Given this list of marker genes TRAFD1, CYP2S1, FBXO45, CD8A, GAS6, PTDSS2, MFSD1, SLC31A1, ARHGAP1, RABGGTA, RNF141, KIN, CBR1, ANKRD28, DPM3, FLOT1, POLR1H, IL1RN, RPGR, DDX19B, MAIP1, S100A1, DNAJC15, MELK, STAB1, ATP5IF1, HMBOX1, TWSG1, MYBPC3, TXNL1, EMP3, SUGT1, DNAJB2, KCNA5, GPM6B, CEBPG, INTS11, PCBP2, PITPNA, SYS1, HK2, KCNMB1, PLA2G7, ABCB8, ZNF644, FH, DYNC1H1, YIPF4, ICE1, GNE, CCN3, GADD45A, CAPN5, MRAS, HAUS6, TMX1, SLC38A4, MCOLN2, VPS37C, PXN, TXNIP, CRCP, GYG1, S100A4, ST3GAL5, USP48, POLG, SAA1, MRPS25, LTC4S, STK16, TEKT2, NFIB, ANXA6, CRYGD, RUFY1, PDE6D, LCP2, GMFG, AGR2, HSD17B11, COX16 (NCBI Gene Id 51241), RMND5A, PAX5, GSTM5, IARS1, ETFB, ID3, GSDME, RPL18, CHMP6, RABGGTB, PGLYRP1, APCS, SLC25A36, FGF18, MRPS11, DAP, FBXL3, RCAN3, BNIP3L, CTDSP2 (NCBI Gene Id 51589), ACIN1, MYD88, GSTO1, EIF3D, GDPD3, LLGL2, IFIT1B, TULP2, PMM2, PKIG, TNFSF4, PDCD4, MYADM, ACAA2, RC3H2, PPIE, FCHO1, BCL2L11, VAMP2, PSTPIP1, HLA-E (major histocompatibility complex, class I, E), USE1, ARNT2, SBF2, RLIM, MYOG, ATF1, SCN1A, CORT, BMP2K, RPL6, PLCG2, NCF4, C19orf73, WNT6, PNLIPRP1, AHNAK, PLXND1, RALGDS, FXYD2, NAPSA, CD1D, ARL2BP, ALOX12, MAP3K1, CYB5B, SNAPIN, CDIP1, TBC1D14, CSDE1, RPL36, STK10, TGFBI, SMARCD1, IDO1, STX12, BARD1 (BRCA1 associated RING domain 1), VWF, COX6A1, KCTD10, PEX11A, NDUFA6, WDR13, PUM2, LPCAT3, MIEN1, KPNA3, PSMD1, ADIPOQ, FASTKD5, ABCC6, ATP4B, RAB3D, LBR, RXRB, RACK1, C2orf80, TMEM9B, CYP51A1, ADRA2A, H1-4, PRX, VMP1, SESN1, GRK6, FBXO9, ANGEL2, SOCS3, CLTC, COLQ, RBM17, CPNE3, SIRT3, NCOA6, BTC, TP53INP2, GLRX3, PNP, here is a description of the gene set: studied in species Homo sapiens Human Gene Set: GSE43955_TGFB_IL6_VS_TGFB_IL6_IL23_TH17_ACT_CD4_TCELL_60H_UP Genes up-regulated in CD4 T helper cells Th17 (60h): TGFB1 and IL6 versus TGFB1, IL6 and IL-23. from publication Yosef N, Shalek AK, Gaublomme JT, Jin H, Lee Y, Awasthi A, Wu C, Karwacz K, Xiao S, Jorgolli M, Gennert D, Satija R, Shakya A, Lu DY, Trombetta JJ, Pillai MR, Ratcliffe PJ, Coleman ML, Bix M, Tantin D, Park H, Kuchroo VK, Regev A (PMID 23467089) Despite their enormous importance, the molecular circuits that control the differentiation of Th17 cells remain largely unknown. Recent studies have reconstructed regulatory networks in mammalian cells, but have focused on short-term responses and relied on perturbation approaches that cannot be applied to primary T cells. Here, we develop a systematic strategy – combining transcriptional profiling at high temporal resolution, novel computational algorithms, and innovative nanowire-based tools for performing gene perturbations in primary T cells – to derive and experimentally validate a temporal model of the dynamic regulatory network that controls Th17 differentiation. The network is arranged into two self-reinforcing and mutually antagonistic modules that either suppress or promote Th17 differentiation. The two modules contain 12 novel regulators with no previous implication in Th17 differentiation, which may be essential to maintain the appropriate balance of Th17 and other CD4+ T cell subsets. Overall, our study identifies and validates 39 regulatory factors that are embedded within a comprehensive temporal network and identifies novel drug targets and organizational principles for the differentiation of Th17 cells.